The following is a description of a gene set: Mouse Gene Set: GOBP_DETERMINATION_OF_DIGESTIVE_TRACT_LEFT_RIGHT_ASYMMETRY studied in species Mus musculus Determination of the asymmetric location of various parts of the digestive tract with respect to the left and right halves of the organism. The digestive tract is the anatomical structure through which food passes and is processed., and this is the list of marker genes: Megf8, Ccdc103, Dnaaf1, Ccdc39, Ccdc40, Zic3, Nphp3